The following is a description of a gene set: Reactome Pathway: Transport of HA trimer, NA tetramer and M2 tetramer from the endoplasmic reticulum to the Golgi Apparatus part of: Assembly of Viral Components at the Budding Site Processed viral proteins are transported from the endoplasmic reticulum to the Golgi apparatus. studied in species Homo sapiens, and this is the list of marker genes: HA, NA, M